The following is a description of a gene set: This event has been computationally inferred from an event that has been demonstrated in another species.<p>The inference is based on the homology mapping from PANTHER. Briefly, reactions for which all involved PhysicalEntities (in input, output and catalyst) have a mapped orthologue/paralogue (for complexes at least 75% of components must have a mapping) are inferred to the other species. species: Mus musculus electronically inferred by orthology from the curated human pathway Reactome Pathway: N-glycan antennae elongation in the medial/trans-Golgi part of: Transport to the Golgi and subsequent modification, and this is the list of marker genes: Fut8 (fucosyltransferase 8), Mgat4c, St8sia3, B4galt6, Chst8, Cga, St8sia2, St3gal4, Man2a1